The following is a description of a gene set: Human Gene Set: FOX_Q2 Genes having at least one occurrence of the motif KATTGTTTRTTTW in the regions spanning 4 kb centered on their transcription starting sites. This matches the FOXF2 transcription factor binding site V$FOX_Q2 (v7.4 TRANSFAC). species: Homo sapiens, and this is the list of marker genes: GFRA1, FKBP14, ZBTB20, RBFOX1, GRIK3, BCOR, C7orf33 (NCBI Gene Id 202865), DOCK3, TPP2, MACROH2A1, PRDX5, PRICKLE2, SCG3, RPS6KB1, TSHZ3, NR4A3, FIRRM, FABP4, NRG1, ZBTB22, NMNAT2, KLHL1, EFNA1 (ephrin A1), FOXP2, POLR3F, SLITRK2, ALDH9A1, HOXA10, CEND1, FGF13, ACACA, ATOH8, PRKAR2B, ERRFI1, NECTIN1, ARK2N, CEBPA-DT, BRIP1, EGFLAM (EGF like, fibronectin type III and laminin G domains), CDH10, PLEKHA8, HTR1B, ATP2A2, STX19, FABP1, ITGA3, NFIA, BCL11B, SPATA18, HOXB3, ESRRG (estrogen related receptor gamma), PDCD4, KRT84, EGR2, H2AZ2, GABARAPL1, TCF7L2, ATXN7L1, PLAG1, ARRB2 (arrestin beta 2), CPNE1, TMEM209, DMD, PURA, MITF, PHEX, PHTF2, OTX2, MCM7, CADPS, CMKLR2 (chemerin chemokine-like receptor 2), RUNX1T1, PALMD, GPRC5C (G protein-coupled receptor class C group 5 member C), GAL3ST4, PPM1D (protein phosphatase, Mg2+/Mn2+ dependent 1D), SCML1, XPO4, CYP26B1, RPL7A (NCBI Gene Id 6130), HMCN1 (NCBI Gene Id 83872), RREB1, NCDN, KCTD4, VAX1, NEO1, TTR, CTCF (NCBI Gene Id 10664), COL13A1, NCAM1, PRMT6, FOXN1, RAB3IP, PRR34, TSHZ2, GCNT2, FBXO11, LGI1, PPP1CB, VGLL3 (vestigial like family member 3), SKIDA1, FZD10, EIF4H (eukaryotic translation initiation factor 4H), EFEMP1, HOXA11, KLF14, UHRF2, METTL18, GDNF, PTGR3, ARHGEF2, SIM1, KLF9, KLF12, CEBPA, RORA, GOLGA1, FAM180A, CADM1, BAMBI, BTBD3, KCNH5, FARP1, EXT1, CSMD3, NHSL2, TNR, ITGBL1, ZIC5, TRMT112, PRG4, PAQR9, MAP2K5, LMO4, ING3, NEUROD2, SLC10A7, GATA6, CRIM1, CPEB4, TBL1X, ATP1B4, COLEC10, SMARCA2, FSTL1, CTHRC1, PREX2, AP4M1, PIK3C2A, ZHX2, UBR1, NTN1, HABP2, UQCRFS1, STAP1, NREP, SLIT3, DNAJB12, CHCHD7, RGMA, NECAB3, MED22, TNFSF10, CNBP, CILK1, EIF4EBP2, RPS6KA5, POGZ, CCND2, TOB1, TET2, IL17C, SLC39A8, SEMA4G, ZNF436, SCUBE3 (signal peptide, CUB domain and EGF like domain containing 3), TMEM185A, SWAP70, NTF3 (neurotrophin 3), PABIR1, CASQ2, NEIL3, HOXD10, PRDM1, SLC20A1, CDKN1A, LINC00299, ZBTB37, HESX1, TGFB3, MAP4K4, IRS4, EBF2, RFX3, TGIF1, MGLL, STOML2, C8orf82, TAPT1, POU4F2, VASN, TWIST1, TRERF1, JUNB, NEBL, TAPT1-AS1, GNAO1, ADAMTS14, NT5C1B, TWIST2, MEF2C, CYP2A7, ANGPTL1, MYT1